Given this list of marker genes Arap1, Ubb, Cbl, Dok1, Rps27a, here is a description of the gene set: This event has been computationally inferred from an event that has been demonstrated in another species.<p>The inference is based on the homology mapping from PANTHER. Briefly, reactions for which all involved PhysicalEntities (in input, output and catalyst) have a mapped orthologue/paralogue (for complexes at least 75% of components must have a mapping) are inferred to the other species. electronically inferred by orthology from the curated human pathway part of: Signaling by PTK6 species: Mus musculus Reactome Pathway: PTK6 Regulates RTKs and Their Effectors AKT1 and DOK1